The following is a description of a gene set: studied in species Homo sapiens Human Gene Set: HP_PYELONEPHRITIS An inflammation of the kidney involving the parenchyma of kidney, the renal pelvis and the kidney calices. Pyelonephritis, and this is the list of marker genes: PKD2, CFI, ZMYM3, ALG9, HOXA13, EFEMP2, ALDH18A1, ELN, GANAB, ALG5, XDH, PKD1, MYH11, DNAJB11, FBLN5, MED12, LTBP1, BNC2 (basonuclin zinc finger protein 2), BICC1, KCTD1, IFT140